Given this list of marker genes PLXNA3, RAC3, ARK2C, SEMA3F, EPHA4, SLIT2, ERBB2, HOXA2, NRP1, KIF5C, EGR2, LHX4, FGF8, NOG, SLIT1, NRP2 (neuropilin 2), LMO4, MYCBP2, CDK5, CHN1, PLXNA4, RAC1, SEMA3A, ALCAM, LHX3, LHX1 (NCBI Gene Id 3975), here is a description of the gene set: Human Gene Set: GOBP_MOTOR_NEURON_AXON_GUIDANCE studied in species Homo sapiens The process in which the migration of an axon growth cone of a motor neuron is directed to a specific target site in response to a combination of attractive and repulsive cues.